The following is a description of a gene set: Cytokines mediate cell-cell communication in the immune system and represent important therapeutic targets. A myriad of studies have highlighted their central role in immune function, yet we lack a global view of the cellular responses of each immune cell type to each cytokine. To address this gap, the authors created the Immune Dictionary, a compendium of single-cell transcriptomic profiles of more than 17 immune cell types in response to each of 86 cytokines (>1,400 cytokine-cell type combinations) in mouse lymph nodes in vivo. A cytokine-centric view of the dictionary revealed that most cytokines induce highly cell-type-specific responses. For example, the inflammatory cytokine interleukin-1β induces distinct gene programmes in almost every cell type. A cell-type-centric view of the dictionary identified more than 66 cytokine-driven cellular polarization states across immune cell types, including previously uncharacterized states such as an interleukin-18-induced polyfunctional natural killer cell state. from publication Cui A, Huang T, Li S, Ma A, Pérez JL, Sander C, Keskin DB, Wu CJ, Fraenkel E, Hacohen N (PMID 38057668) Genes positively differentially expressed in cell type: pDC (plasmacytoid dendritic cell) upon treatment with cytokine: RANKL in mouse lymph nodes in vivo. studied in species Mus musculus Mouse Gene Set: CUI_PDC_RANKL_RESPONSE_UP, and this is the list of marker genes: Fchsd2, Nolc1, Plagl2, Med29, Znfx1